Given this list of marker genes B3gat3, Hyal5, Has2, Naglu, Pglyrp4, Ndst2, Hyal1, Hyal6, Has1, Csgalnact2, Hs3st2, Nfkb1, Dsel, Chst3, Lyg1, Slc35d1, Pdgfb, Slc9a1, Galns, Hexb, Has3, Gusb, Chst13, Hyal2, Xylt2, Bpnt2, Cemip, Stab2, Ext1, Pxylp1, Ptger4, Smpd3, Hs3st1, Hyal4, Itih3, Csgalnact1 (chondroitin sulfate N-acetylgalactosaminyltransferase 1), Abcc5, Igf1, Chst12, Hs3st3b1, Chst7, Chst11, Cytl1, Itih4, B4galnt4, Chsy1, Pglyrp3, Hmmr, B4galnt3, Chsy3, Cln6, Il15, Egf, Itih5, Cemip2 (NCBI Gene Id 83921), Fgf2, Chpf2, Cd44, Pglyrp2, Hexa, Il1b, Arsb, Pdgfrb, B3gat1 (beta-1,3-glucuronyltransferase 1), Chpf, B3gat2, Hyal3, Galnt3, B3galt6, Tnfaip6, Pglyrp1, Sgsh, Slc35b2, Ap2a1, Habp4, Hs3st3a1, Ids, B4galt7, Ext2, Ccnd3, Lyg2, Idua, Lyve1, Spam1, Tgfb1, Itih1, Cltc, Itih2, Ndst1, Xylt1, Ugdh, Dse, Foxc1, here is a description of the gene set: species: Mus musculus Mouse Gene Set: GOBP_GLYCOSAMINOGLYCAN_METABOLIC_PROCESS The chemical reactions and pathways involving glycosaminoglycans, any of a group of linear polysaccharides composed of repeating disaccharide units.